Given this list of marker genes Maoa, Gmppa, Plaa, Rassf4, Rsu1, Rabepk, Abraxas1, Bloc1s4, Chst14, Cul5, Cebpz, Ydjc, Ubfd1, Eif6, Casp7, Zfp266, Tmem186, Atl3, Plac8 (placenta-specific 8), Ccnq, Ssr2, 1700129C05Rik, Galk1, Slc35b2, Mrps25, Wdr77, Lman2, Sdf2l1, Pla2g4d, Aagab, Zfp706, Polr3e, Mdh1, Qars1, Mrps35, Tamm41, Gtf3a, Atp6ap2, Parl, Ctsz, Gcnt3, Papss2, 2210408I21Rik, Pgam1, Bid, Mapre2, Pcca, Nostrin (nitric oxide synthase trafficker), Isg20l2 (interferon stimulated exonuclease gene 20-like 2), Scin, Ddx52, Cdadc1, Sco1, Cisd1, Bloc1s2, Trappc13, Cbln3, Pes1, Chchd4, Prag1, Txndc15, Ddx20, Elane, Myg1, Elp2, Naa50, Thoc5, Luc7l, Commd10, Bet1, Gpt2, Dnlz, Agpat5, Mtg1, Wdr73 (WD repeat domain 73), AI506816, Sfxn4, Sel1l2, Gusb, Apex1, Trmt6, Gpr180, Fam149b, Nebl, Ssr1, Cluap1, Aldoa, Pycard, As3mt, Pfkp, Afap1, Ahcyl, Enoph1, Polr3c, Smim40, Tex2, Gfm1, Tmem178, Abi3, Tns3, Rpn1, Dhx37, Fancm, Ercc8, Noc3l, Spcs3 (signal peptidase complex subunit 3 homolog (S. cerevisiae)), Dbi, Nol9, Psma3, Mapkapk3 (mitogen-activated protein kinase-activated protein kinase 3), 3110082I17Rik, Dync2i2, Ermard, Snupn, Gtpbp8, Erlin1, Eef1b2, Zfp583, Desi2, Utp25, Erp44, Cited2, Surf6, Map3k20, Klhl23, Apip, Armt1, Tbrg4, G3bp1, Nipsnap3b, Mrpl12, Dtx4, Tmem97, Npc2, Mfsd10, Siglecf, Ap3s2, here is a description of the gene set: Mechanisms regulating self-renewal and cell fate decisions in mammalian stem cells are poorly understood. We determined global gene expression profiles for mouse and human hematopoietic stem cells and other stages of the hematopoietic hierarchy. Murine and human hematopoietic stem cells share a number of expressed gene products, which define key conserved regulatory pathways in this developmental system. Moreover, in the mouse, a portion of the genetic program of hematopoietic stem cells is shared with embryonic and neural stem cells. This overlapping set of gene products represents a molecular signature of stem cells. studied in species Mus musculus Mouse Gene Set: IVANOVA_HEMATOPOIESIS_INTERMEDIATE_PROGENITOR Genes in the expression cluster 'Intermediate Progenitors Shared': up-regulated in hematopoietic intemediate progenitor cells from adult bone marrow and fetal liver. from publication Ivanova NB, Dimos JT, Schaniel C, Hackney JA, Moore KA, Lemischka IR (PMID 12228721)